The following is a description of a gene set: Human Gene Set: GOBP_VITAMIN_E_METABOLIC_PROCESS The chemical reactions and pathways involving vitamin E, tocopherol, which includes a series of eight structurally similar compounds. Alpha-tocopherol is the most active form in humans and is a powerful biological antioxidant. species: Homo sapiens, and this is the list of marker genes: NPC1L1 (NCBI Gene Id 29881), TTPA, PLTP, CYP4F12, NQO1, CYP4F2